Given this list of marker genes MTRR, MTR, here is a description of the gene set: Reactome Pathway: Defective MTRR causes HMAE studied in species Homo sapiens part of: Defects in cobalamin (B12) metabolism Defects in MTRR cause methylcobalamin deficiency type E (cblE; methionine synthase reductase deficiency; MIM:236270). Patients with cblE exhibit megaloblastic anemia and hyperhomocysteinemia. SAM is used as a methyl donor in many biological reactions and demethylation of SAM produces S-adenosylhomocysteine, which is deadenosylated to form homocysteine. Homocysteine remethylation is carried out by MTR, which requires MTRR to maintain enzyme-bound cobalamin (Cbl) in its active form; but in cblE patients, MTR becomes inactivated and thus homocysteine accumulates.